Given this list of marker genes STXBP1, RAB3A, STXBP2, SNAP25, STXBP3, here is a description of the gene set: The secretion of molecules (e.g. neuropeptides and neuromodulators such as serotonin and dopamine) contained within a membrane-bounced dense in response to increased presynaptic cytosolic calcium levels. Human Gene Set: GOBP_PRESYNAPTIC_DENSE_CORE_VESICLE_EXOCYTOSIS species: Homo sapiens